The following is a description of a gene set: Any process that activates or increases the frequency, rate or extent of intrinsic apoptotic signaling pathway by p53 class mediator. Human Gene Set: GOBP_POSITIVE_REGULATION_OF_INTRINSIC_APOPTOTIC_SIGNALING_PATHWAY_BY_P53_CLASS_MEDIATOR studied in species Homo sapiens, and this is the list of marker genes: RPL26, MYC, TP53BP1, EIF5A, TP73, MIR186, RPS7, UBB, MSX1